Given this list of marker genes Acan, Sparcl1, Vcan, Rbp3, Ptprz1, Hapln4, Bcan, Hapln3, Zp3, Ncan, Impg1, Hapln2, Zp1, Zp2, Tnc (tenascin C), Lama5, Hapln1, Impg2, Rtbdn, Ovgp1, Tnr, here is a description of the gene set: Mouse Gene Set: GOCC_SPECIALIZED_EXTRACELLULAR_MATRIX Species or cell-type specific extracellular matrices that are different from the two main types of extracellular matrices: the interstitial ECM and the basement membrane ECM in metazoa. species: Mus musculus